The following is a description of a gene set: species: Homo sapiens from publication Aizarani N, Saviano A, Sagar, Mailly L, Durand S, Herman JS, Pessaux P, Baumert TF, Grün D (PMID 31292543) Human Gene Set: AIZARANI_LIVER_C22_RESIDENT_B_CELLS_2, and this is the list of marker genes: MZB1, HSP90B1, SPCS2, PLPP5, BTG2, HERPUD1, MEI1, HLA-DOB, CD79A, ITM2C, SEC11C, BLOC1S5-TXNDC5, XBP1, SLAMF7, POU2AF1, DERL3, FOSB, CRELD2, FCRL5, CREB3L2, PTK2B, FKBP11, TENT5C, ERLEC1, CD27, AMPD1, RAB30, SSR4, PRDX4, TSC22D3, SDF2L1, H1-10, LY9